The following is a description of a gene set: Vitamins Mouse Gene Set: REACTOME_VITAMINS studied in species Mus musculus, and this is the list of marker genes: Cyp24a1 (NCBI Gene Id 13081), Cyp27b1, Cyp2r1, Cyp26a1, Cyp26c1, Cyp26b1